The following is a description of a gene set: Axonal degeneration studied in species Homo sapiens Human Gene Set: HP_AXONAL_DEGENERATION, and this is the list of marker genes: DNM2, LRSAM1, ABCD1, SEPTIN9, GDAP1, SH3TC2, TRIM2, SERPING1, ERCC6 (ERCC excision repair 6, chromatin remodeling factor), CTDP1, APTX, SETX (NCBI Gene Id 85506), LMNA, TFG, FLVCR1, IGHMBP2, REEP1, SLC25A21, NAGA, GJB1, LAMA2, CYP27A1, TXN2